The following is a description of a gene set: Human Gene Set: WP_INFLUENCE_OF_LAMINOPATHIES_ON_WNT_SIGNALING Influence of laminopathies on Wnt signaling studied in species Homo sapiens, and this is the list of marker genes: RUNX2, GSK3B, TCF7L1, ADIPOQ, TCF7, MIR33B, SPP1, AXIN1, DICER1, CDK6, CEBPA, SLC2A4, LMNA, HES1, SREBF1, TOR1AIP1, CCND1, CSNK1A1, HMGA2, LEF1, TARBP2, MIRLET7B, CEBPB, WNT10B, TLE1, CTNNB1, APC, HES5, EMD, TCF7L2, AGO2, ZMPSTE24, CSNK1A1L, CEBPD, ICMT, PPARG, FNTA